Given this list of marker genes FANCE, UBE2T, DCLRE1B, FANCF, FANCI, FANCL, FANCA, BRIP1, RAD51, FANCC, BRCA2 (NCBI Gene Id 82716), PALB2, COX4I1, FANCD2, SLX4, MAD2L2, here is a description of the gene set: Human Gene Set: HP_CHROMOSOMAL_BREAKAGE_INDUCED_BY_CROSSLINKING_AGENTS Increased amount of chromosomal breaks in cultured blood lymphocytes or other cells induced by treatment with DNA cross-linking agents such as diepoxybutane and mitomycin C. species: Homo sapiens Chromosomal breakage induced by crosslinking agents